The following is a description of a gene set: Human Gene Set: KEGG_MEDICUS_ENV_FACTOR_TCDD_TO_AHR_SIGNALING_PATHWAY studied in species Homo sapiens Pathway Definition from KEGG: TCDD -> (AHR+ARNT) => (CYP1A1,CYP1B1,GST) TCDD to Ahr signaling pathway. Pathway ID: N01365. Pathway type: Env factor. Pathway class: nt06227 Nuclear receptor signaling., and this is the list of marker genes: CYP1B1, GSTT1 (NCBI Gene Id 2952), GSTP1, GSTA3, GSTA2, GSTM5, GSTT2, MGST3, GSTA4, GSTO1, AHR, GSTO2, GSTM3, MGST2, GSTM4, GSTA1, MGST1, GSTM1, GSTT2B, GSTA5, ARNT, CYP1A1, GSTM2